Given this list of marker genes RACK1, PLXNA3, MIR17HG, PSRC1, PTPRJ, CYP27B1, SPHK2, CDA, ACVR1B, RGS4, RBBP7, STK4, SPP1, SOX17 (NCBI Gene Id 64321), NME6, BDKRB1, EAF2, CCAR2, BCL11A, DCUN1D3, ADRB2, HNF4A, RB1, SESN1, CDKN2A, ADIPOR1, PI16, WNT3A, G6PD, OSGIN1, FSTL4, PPARD, CDKN2D, OSTN, PTEN, SAV1, TP53, MT1E, PPP1R9B, CGRRF1, CRLF3, NPPA, BTG1, GDF15, NTN1, RGMA, TRIM40, NRP1, HIF1A, CCDC85B, ING5, MSTN, BMP10, CAV3, BCL6, CFL1, CAPRIN2, CRYAB, LGMN, PHB1, SPART, SCGB3A1, RTN4R, MINAR1, TSPYL2, PML, CDKN1B, MT1G, SMAD4, DCC, SLIT1, EPHA7, SIPA1, P3H1, BRCA1, NPR1, GJA1, EI24, TLL2, FXN, BBS2, NAIF1, MSX1, RNF6, PAK1, WNT5A, TRIM46, TCHP, MAG, PPARA, STK3, PTPRS, MYL2, CDHR2, TGFB1, IFRD1, RAI1, GPC3, DCSTAMP, SERTAD2, ING1, ST7L, HSPA1A, GDF9, SEMA4F, NOG, STC2, GNG4, ALOX15B, SPAG9, WT1, GDF2, PPT1, CDK5, MAP2, SLIT3, CDKL3, ACVRL1, ULK2, TP53TG5, MIR1-1, SFRP2, TBX5, SFRP1, MT2A, MIR199A1, SEMA3F, SH3BP4, YY1, SESN2 (sestrin 2), SOCS2, HDAC6, RYK, FHL1, FRZB, TP73, DACT3, DRAXIN, VGLL4, MIR25, SEMA5A, ULK1, GSK3A, TMEM196, BCL2 (BCL2 apoptosis regulator), MYOZ1 (myozenin 1), DDX3X, PTK6, IP6K2, ADRB3, BST2, RERG, MIR199B, CDKN1A, SLIT2, ATG16L1, DAB2 (DAB adaptor protein 2), WWC2, FGF13, CDKN2C, ZC3H12D, TGFB2, PLAC8, IGFBP5, FOXP1 (NCBI Gene Id 87246), RGS2, ENPP1, CTDP1 (NCBI Gene Id 9150), RBP4, DUSP10, JARID2, MEG3, KCNK2, JADE1 (NCBI Gene Id 79960), SLC6A4, DCBLD2, MT3, ENO1, CDH1, SEMA6C, MIR873, MT1A, HYAL1, CDKN2AIP, CGA, SERPINE2, MT1M, RTN4, MT1B, CCN3, MAPK11, GNAS, STK11, HSPA1B, AGTR2, FBP1, WWC1, SERTAD3, ADRB1, SMARCA4, FGFR3 (fibroblast growth factor receptor 3), KIAA0319, TOMM70, NDRG3, DNAJB2, DIP2B, WWC3, HRG, MT1H, ING4, NPPB (NCBI Gene Id 4879), ARHGAP4, WFDC1, TMPRSS4, BMPR2, INHBA, PTCH1, PRDM11, MT1X, MIR200B, OSGIN2, SMAD3, TNR, HYAL2, ESR2, ADAM15, SEMA6D, WNT3, SMARCA2, SEMA3G, MT1F, here is a description of the gene set: Human Gene Set: GOBP_NEGATIVE_REGULATION_OF_GROWTH species: Homo sapiens Any process that stops, prevents or reduces the rate or extent of growth, the increase in size or mass of all or part of an organism.